The following is a description of a gene set: Human Gene Set: HP_MYOCLONIC_SEIZURE species: Homo sapiens A myoclonic seizure is a type of motor seizure characterized by sudden, brief (<100 ms) involuntary single or multiple contraction of muscles or muscle groups of variable topography (axial, proximal limb, distal). Myoclonus is less regularly repetitive and less sustained than is clonus. Myoclonic seizure, and this is the list of marker genes: PLAGL1, GCSH, MT-ND3, CAMK2A (calcium/calmodulin dependent protein kinase II alpha), SLC6A1, RTN4IP1, ALDH7A1, MT-ND2, KCTD7, MT-TS2, PTRH2, MT-ND5, PCDH12, SYNGAP1, HCN1, ARFGEF1, KCNC1, CLCN3, GPHN, NGLY1, ARX, NEUROD2, EXTL3, KCNQ2, MFSD8, SLC12A5, CSNK2B, GRN, KCNA2, EEF1A2, ASAH1, CAMTA1, MT-TP, HID1, DNM1, ATP5F1E, PDX1, TSEN15, SCN8A, DNM1L, AARS1, CACNA1C, MT-TW, CLN8, CLCN2, MT-TL1, NUS1, DALRD3, DHFR, GABRA1, HEXB, GRIN2A, STX1B, TSEN54, SCN1A, ATP5MK, GRIK2, HACE1, SETD1B, DHDDS, VPS53 (VPS53 subunit of GARP complex), COG3, SEPSECS, KCNT2, ST3GAL3, PPP1R21, MTHFR, CLPB, TRIT1, CASK, DENND5A, MED11, FZR1, NAXE, BUB1B, APC2, SMC1A, EXOC8, SCN2A, MT-TK, MBOAT7, BCKDK, DYRK1A, POU4F1, ADGRG1, GOSR2, ATP5F1D, PLPBP, MT-TI, PTPN23, NTNG1, PTEN, PHGDH, MT-ND1, ALG13, KCNMA1, GLUL, SLC32A1, TSEN34, NDUFV1, KCNA1, SLC25A15, PRRT2, FARS2, ROGDI, PIK3CD, KCNC2, SMS, DMXL2, CUX2, PACS2, UFC1, CACNA1A, GABRD, RAB18, DPM2, SATB1, CACNA1B, EXOC7, PPP3CA, KCNT1, MT-TH, MT-TF, GRM7, CTNNA2, ATP6V1A, EFHC1, PIGP, AFG3L2, AFG2A, CDC40, KIF11, COL18A1, NEXMIF, ABCC8, TANGO2, PRDM8, GCK, SLC38A3, GAMT, ELOVL4, SIK1, EXOSC5, NARS1, MT-ND6, SDHB, DNAJC5 (NCBI Gene Id 80331), OPHN1, MRAP, ZNF526, PIGL, NDE1, INS, CPLX1, SDHA, AFG2B, PRUNE1, MAST3, TBC1D24, GNAO1, SCN9A, ADGRV1, MDH2, SLC25A22, CDKL5, HYMAI, TSEN2, BRAT1, ATPAF2 (NCBI Gene Id 91647), PYCR2, DPAGT1, NBEA, NHLRC1 (NCBI Gene Id 378884), KCNQ3, PIGQ, SPTAN1, NDUFA1, CTSD, GNB1, GAD1, CEP85L, CACNA1D, SCN1B (NCBI Gene Id 6324), GRIN1, GABRA5, STXBP1 (NCBI Gene Id 6812), ALDH5A1 (aldehyde dehydrogenase 5 family member A1), MT-ND4, MAPK10, CARS2, NSD1, FBXO28, CILK1, DPM1, MT-TV, FGF13, NDUFAF3 (NADH:ubiquinone oxidoreductase complex assembly factor 3), SLC2A1, LMNB2, PPFIBP1, GBA1, KNSTRN, MT-TQ, MECP2, PI4K2A, AP2M1, EPM2A, GLB1, GABRB3, SLC1A2, PLCB1, CRELD1, KCNJ11, IER3IP1, PCDH19, RFX7, NEU1, PSAP, POLG, PNKP, YWHAG, ATP6V0C, SDHAF1, ATP5F1A, GALC, D2HGDH, CHD2, SV2A, ACBD6, DPH5, STAT3, SYNJ1, NCDN, SDHD, SAMD12, GPAA1, CNPY3, PIGT, PAFAH1B1, PPIL1, AP3D1, CHD3, GABRG2, PGAP2, MACF1, EIF4A2, GRIN2B, BTD, GABBR2, HCN4, GM2A, MICOS13, PIGH, TRAPPC9, RBL2, LNPK, TRIM8, PIGA, COX8A, PGAP3, KCNH5 (NCBI Gene Id 27133), MT-ATP6, NEUROG1, MT-RNR1, TGFB1 (NCBI Gene Id 7040), PRICKLE1, MT-ATP8, CIC